The following is a description of a gene set: Mouse Gene Set: GOBP_REGULATION_OF_RESPONSE_TO_ENDOPLASMIC_RETICULUM_STRESS studied in species Mus musculus Any process that modulates the frequency, rate or extent of response to endoplasmic reticulum stress., and this is the list of marker genes: Ikbkg, Akt3, Tmx1, Hyou1, Manf, Creb3l1, Usp25, Atad3a, Rnft2, Atf6b, Igtp, Bak1, Nr1h3, Creb3, Usp19, Rnf183, Ubxn2a, Atf6, Nck2, Tmbim6, Nck1, Crebrf, Syvn1, Bcap31, App, Svip, Prkn, Bfar, Bax, Fcgr2b, Stub1, Wfs1, Cops5, Usp13, Alox5, Serinc3, Rnf185, Atxn3, Opa1, Akt1, Tmem259, Bcl2l1, Aqp11, Sgta, Nfe2l1, Selenos, Xbp1, Bag6, Rnft1, Ficd, Ptpn2, Mbtps2, Spop, Nupr1, Abca7, Lrrk2, Herpud1, Eif2ak3, Erp29, Lpcat3, Eif2a, Nr1h2, Pik3r1, Ubxn1, Ufl1, Sirt1, Ddrgk1, Ern1, Cav1, Tmem33, Ptpn1, Tmem67, Clu, Pdia6, Pdx1, Txndc12, Pigbos1, Ubqln1, Ubqln2, Agr2, Akt2, Dnajb9, Bok, Hspa5, Grina, Park7, Usp14